Given this list of marker genes Fas, Ripk1, Cflar, Fadd, Casp8, Casp3 (caspase 3), here is a description of the gene set: Mouse Gene Set: GOCC_DEATH_INDUCING_SIGNALING_COMPLEX studied in species Mus musculus A protein complex formed by the association of signaling proteins with a death receptor upon ligand binding. The complex includes procaspases and death domain-containing proteins in addition to the ligand-bound receptor, and may control the activation of caspases 8 and 10.